Given this list of marker genes Gas6, Jam2, Jam3, Ext1, Enpp1, here is a description of the gene set: The orderly movement of a hematopoietic stem cell into the bone marrow, and its subsequent positioning within defined functional compartments in that microenvironment. A hematopoietic stem cell is a cell from which all cells of the lymphoid and myeloid lineages develop, including blood cells and cells of the immune system. Mouse Gene Set: GOBP_HEMATOPOIETIC_STEM_CELL_MIGRATION_TO_BONE_MARROW studied in species Mus musculus